The following is a description of a gene set: The process whose specific outcome is the progression of the stem cell over time, from its formation to the mature structure. Cell development does not include the steps involved in committing a cell to its specific fate. studied in species Homo sapiens Human Gene Set: GOBP_STEM_CELL_DEVELOPMENT, and this is the list of marker genes: SOX10, TWIST1, EDNRA, SOX9, SEMA3B, EFNB1, NRP2, TAPT1, BMPR1A, SEMA5B, SEMA4B, SEMA6C, RADIL, MSI2, GDNF, CITED2, PHACTR4, FOXC1, NRP1, BCL2, SEMA4F, SEMA3E, SMO, SEMA4C, KITLG, EDN1 (NCBI Gene Id 1906), PHOX2B, FGF2, ARB2A, SEMA3G, KBTBD8, KLHL12, CDC42, LAMA5, SHH, CDH2, WNT7A, FOLR1, PTPRC, SEMA3D (semaphorin 3D), PEF1, FGF19, SNAI2, FN1, FOXC2, HIF1A, ISL1, ZEB2, NRG1, SEMA3F, GBX2, SEMA7A, NOLC1, ALDH1A2, TCOF1, EDNRB, OVOL2, EDN3, TBX1, RET, RDH10, MAPK1 (NCBI Gene Id 5594), SOX8, PDCD6, CYP26C1, MAPK3, JAG1, BMP7, HES1, HAND2, SEMA6B, ACVR1, SEMA4A, CFL1, SEMA3C (NCBI Gene Id 222200), SEMA6A, SEMA4D, SEMA5A, ERBB4, BMP4, SEMA3A, PITX2, SEMA6D, NRTN, CORO1C, ALX1, HTR2B, SEMA4G, ENG